The following is a description of a gene set: species: Homo sapiens A highly conserved protein complex comprised of two ATP-dependent DNA helicases (Rvb1p and Rvb2p in yeast, Pontin52 and Reptin52 in humans), Pih1p in yeast or PIH1D1 in humans, and Tah1 in yeast or RPAP3 in humans. The complex associates with Hsp90 and is thought to have a role in assembly of large protein or protein/nucleic acid complexes. In this role it is involved in multiple processes such as box C/D snoRNP biogenesis, phosphatidylinositol-3 kinase-related protein kinase (PIKK) signaling, RNA polymerase II assembly, and others. Human Gene Set: GOCC_R2TP_COMPLEX, and this is the list of marker genes: PIH1D2, RUVBL1, RUVBL2, PIH1D1 (PIH1 domain containing 1), RPAP3